Given this list of marker genes DCTD, NUDCD1, C18orf54, PRKACB, ERBB4, TRIB2, PGGT1B (NCBI Gene Id 91374), SLC30A1, FKBP9, GPR146, LHFPL1, ABCE1, ACVR2A, MAP4K5, INO80, KMT2E, THUMPD2, SYT1, MMD2, SPX, FAM168B, STARD4, PANK3, GIT1, STAM, MAPK10, GIMAP2, YPEL1, USP10, CBFB, PDE10A, TMEM165, PLAG1, GPATCH2L, CEP95, ZNF662, ZNF736, DCAF7, SLC10A7, MED21, SOS2, KANK2, MLLT3, CCNJL, GPRC5B, MAPK8, ANK3, HOXC6, ZDHHC18, DLL1 (delta like canonical Notch ligand 1), ZNF248, PPARGC1A, ARHGAP19, SPRR2A, SOCS6, GBP6, MRPL48, DNAJB9, CLOCK, BRD10, IGSF3, CCDC186, ZNF644, EIF4EBP2, LRATD1, APLN, RNF138, ESRRG (estrogen related receptor gamma), ETS1, SLC9A3, SMAP1, IFNW1, IGF2BP1 (NCBI Gene Id 201194), METTL8, AMMECR1, SS18, TIMP3, here is a description of the gene set: species: Homo sapiens Genes predicted to be targets of miRBase v22 microRNA hsa-miR-892b in miRDB v6.0 with MirTarget v4 prediction scores > 80 (high confidence targets). Human Gene Set: MIR892B from publication Chen Y, Wang X (PMID 31504780)